The following is a description of a gene set: Any process that modulates the frequency, rate or extent of the chemical reactions and pathways by which individual cells transform amines. studied in species Mus musculus Mouse Gene Set: GOBP_REGULATION_OF_AMINE_METABOLIC_PROCESS, and this is the list of marker genes: Park7, Htr2c, Snca, Tacr3, Epas1, Drd4, Pnkd, Comt, Gpr37, Nr4a2, Vhl, Htr1a (5-hydroxytryptamine (serotonin) receptor 1A), Abat, Npy, Fshr, Atp2b4, Slc6a3, Vps35, Drd1, Atp7a, Itgam, Chrnb2, Pebp1, Hprt1, Aldh2, Maob, Prkn, Paox